The following is a description of a gene set: Thoracic hypoplasia Human Gene Set: HP_THORACIC_HYPOPLASIA studied in species Homo sapiens, and this is the list of marker genes: PIK3CA, IFT43, SERPINH1, TOMM7, TMCO1, FLNB (filamin B), IL6ST, HSPG2, CILK1 (ciliogenesis associated kinase 1), GPX4, IHH, ACTG2, FAT4, CCBE1, FGFR2, GNPTAB, KYNU, MTOR, KLHL41, CRTAP, IFT80, NAA10, CHST3, ABCC9, INTU, SNRPB, ZBTB20, GAD1, RTL1, ACTA1, DYNLT2B, PRKACB, CFL2, ADAMTS3, DYNC2LI1, IFT52, DYNC2I2, SBDS, TBX5, DDRGK1, B4GALT7, COL2A1, IFT140, PIGN (NCBI Gene Id 23556), SRP54, XYLT1, FBN1, RMRP, CREB3L1, ATP7A, TCIRG1, EVC, MYPN, MBTPS2, SLC35D1, CCN2, FAM20C, KAT6A, SKI (SKI proto-oncogene), PCGF2, GBA1, TWIST1, BMPER, KIAA0586, DLK1, CSPP1, SLC37A4, MED12, SNX10, IFT172, ITGA3, GLI1, BCOR, NEK1, ZC4H2, TPM3, UPF3B, DONSON, MUSK, MEG3, AGRN, TRIP11, LMNA, IFT81, TTC21B, GNE, PPIB, TAPT1, FGFR3, COL1A2, COL11A2, PCNT, PRKACA, POR, LMOD3, LBR (NCBI Gene Id 653311), HSD17B4, NEPRO, PAM16, CFAP410, CEP120 (NCBI Gene Id 153241), DYNC2I1, FLNA, DCHS1, TAF4, TRPV6, STX5, SEC23A, MESD, COL11A1, NEB, DYNC2H1, PIGA, HHAT, DNAJC21, KIAA0753, TPM2, CCDC47, SLC26A2, KBTBD13, EVC2, SLC10A7, NEK9, DLG3, CANT1, PLCB3, PIK3C2A, DDR2, MYOD1, CTSK, COL1A1, TCTN2 (tectonic family member 2), WDR35, MATN3, B3GAT3, SOX9 (NCBI Gene Id 6662), RUNX2, WDR11, POLR3A, RPS19 (ribosomal protein S19), CASR, DDX3X, CLCN7, SCN4A, INPPL1, PTH1R, PUF60, TNFSF11, KCNJ8, TRPV4, IFT122, WDR19, SLC9A6, ORC6